Given this list of marker genes HSPD1, AARS1, GJC2, KIF1C, TTPA (NCBI Gene Id 7274), LMNB1, LAMA1, SPG11, RNU12, HIBCH, PLP1, SPTBN1, EIF2AK2, VPS13A, PI4KA (phosphatidylinositol 4-kinase alpha), PIGA, KARS1, UCHL1, SPTLC1, FUS, SIGMAR1, NKX6-2, TMEM63A, POLR1A, ALS2, here is a description of the gene set: Head titubation Human Gene Set: HP_HEAD_TITUBATION A head tremor of moderate speed (3 to 4 Hz) in the anterior-posterior direction. species: Homo sapiens